Given this list of marker genes Igfbp3, Vegfa, Igfbp6, Igfbp5, Igf1, Igfals, Pdgfa, Pdgfb, here is a description of the gene set: A protein complex that has growth factor activity. studied in species Mus musculus Mouse Gene Set: GOCC_GROWTH_FACTOR_COMPLEX